The following is a description of a gene set: from publication Cui A, Huang T, Li S, Ma A, Pérez JL, Sander C, Keskin DB, Wu CJ, Fraenkel E, Hacohen N (PMID 38057668) Mouse Gene Set: CUI_NK_CELL_IL11_RESPONSE_UP Genes positively differentially expressed in cell type: NK cell upon treatment with cytokine: IL-11 in mouse lymph nodes in vivo. Cytokines mediate cell-cell communication in the immune system and represent important therapeutic targets. A myriad of studies have highlighted their central role in immune function, yet we lack a global view of the cellular responses of each immune cell type to each cytokine. To address this gap, the authors created the Immune Dictionary, a compendium of single-cell transcriptomic profiles of more than 17 immune cell types in response to each of 86 cytokines (>1,400 cytokine-cell type combinations) in mouse lymph nodes in vivo. A cytokine-centric view of the dictionary revealed that most cytokines induce highly cell-type-specific responses. For example, the inflammatory cytokine interleukin-1β induces distinct gene programmes in almost every cell type. A cell-type-centric view of the dictionary identified more than 66 cytokine-driven cellular polarization states across immune cell types, including previously uncharacterized states such as an interleukin-18-induced polyfunctional natural killer cell state. species: Mus musculus, and this is the list of marker genes: Lamtor4, Ide, Agpat3, Gzma (NCBI Gene Id 14938), Nes, Gmfb, Klrg1, Ptp4a3, B3gat3, Cotl1, Nkg7